The following is a description of a gene set: Mouse Gene Set: RFX2_TARGET_GENES Genes containing one or more binding sites for (Rfx2) in their promoter regions (TSS -1000,+100 bp) as identified by GTRD version 20.06 ChIP-seq harmonization. from publication Yevshin I, Sharipov R, Kolmykov S, Kondrakhin Y, Kolpakov F (PMID 30445619) species: Mus musculus, and this is the list of marker genes: H13, Lrrc49, Mir592, Prkn, Kmt5c (lysine methyltransferase 5C), Gm13856, Pkig, Fez1, Dnah7c, Brca1, Eif4a3, Phc1, E2f5, Zfp688, Calm3, Dyrk3, Ube2u, Ahi1, Get3, Wdr73, Gm19412, 4933427D14Rik, Plcb2, Drc1 (NCBI Gene Id 381738), Tmem270, Lrif1, Ube2o, Pms2, Mir207, Pramel12, Abl1, Krt39, Tnnt2, Eno1b (enolase 1B, retrotransposed), Ctxn2, Mypop, Celf6, Pole3, Lyrm1, Oasl1, 4930419G24Rik, Mtx1, BC048559, Oxnad1, Cby1, Cacybp, Rps3, Atp2b4, Set, 4930455B14Rik, Cfap410, Fam216a, Nsdhl, Wdtc1, Nap1l1, Spats1, Kcnj9, Poli, Cetn2, Iqca1, 4930535L15Rik, Lekr1, Ankrd45, Ccnc, Gm8232, Glb1l2, Ttll3, Gtf2e2, Fscn1, Taok2, Dnal1, Alg12 (ALG12 alpha-1,6-mannosyltransferase), Pank2, Agbl2 (NCBI Gene Id 271813), 1810064F22Rik, Chct1, Mks1 (NCBI Gene Id 380718), Bbs12, Slc25a46, Phc2, Gm1758, Odad3, Spag6l, Cbx8, Dpy19l2, Agtrap (angiotensin II, type I receptor-associated protein), Ak8, Tektl1, Kif3b (NCBI Gene Id 99398), 1700001O22Rik, Tmem107, 4930555B12Rik, Mib2, Zc2hc1c, Gm568, Cep57l1, Gm20716, Me3, Fam229b, Csnk1d, Pkp4, Hras (NCBI Gene Id 15461), Folh1, Mrps9, Psmd13, 1700041I07Rik, Eif2b2, Dctn3, Slc25a3, 1700010I14Rik, Trim2, Ddx41, Pak1ip1, Tsnaxip1, Mocs3, Stk11ip, 1700055D18Rik, Med31, Cinp, Cep290, Map1a, Rps27, Pex11g, Cfap44, Ptges3l, Gm15350, Gzmk, Dpf3, Mlf1, Fam90a1b, Nsmce1, Safb2, Mns1, E330034G19Rik, Ldhal6b, Lrrc46, 4933407I08Rik, Drc3, Gm12474, Rbm5, Gm42722, Cherp, Smg7, Spata7 (spermatogenesis associated 7), Ndufa13, 2810414N06Rik, Srfbp1, Gabarapl2, Kcnip3, 4921504E06Rik, Trip12, Dxo, Fsip1, Pcm1, Spag8, Samd15, Nek2, 4930466I24Rik, Tdrp, Adissp, Iqce, Tiam1, Ube4b, Gtf3c1, Wdr7, Hnrnph2, Smim45, 4930579K19Rik, Mroh9, Zbtb5, Ift172, Zfp667, Eif2s1, Dclre1b, Miat, Mtmr12, Rptoros, 4933417C20Rik, Cdk9, Gm17494, Kcnip2, Stx8, Wdr48, Rnf5, Gm36017 (predicted gene, 36017), Mir1955, Nudc, Ubxn2b, 1700040K01Rik, Tmtc3, 1700023H06Rik, Ttc27, Ap2b1, 2810402E24Rik, Npcd, 1700012B09Rik, Nqo1, 4930507D05Rik, Med25, Zfp664, Akap3, Usp22, 1700029M20Rik (RIKEN cDNA 1700029M20 gene), Cep112, Spmip11, Lca5, Aagab, Cenpj (NCBI Gene Id 219103, centromere protein J), 1700030K09Rik, Yjefn3, Cdiptos, Tbc1d31, Apoo, Ccdc157, Speer4b, Cfap73, 4933405L10Rik, 4930478M09Rik, Dnajc30, Map3k14, Rab27a, Cep162, Pnma8a, Enpp2, Strn4, Bbs4, 1700034J05Rik, Sec16a, Mfsd6, Prepl, Tspyl4, Rgl1, Mir6913, Moap1, Msmo1, Mir7045, Atxn7l1os2, Ino80e, Taf11, 1700028N14Rik, Fam161a, Cep295nl (CEP295 N-terminal like), Fto, Lrrc43, Cfap91, Ufm1, Spmap2l (NCBI Gene Id 71868), Sirt2, Gm11444, Spindoc, Pagr1a, 4933424G06Rik, Gm32780, Jun, Pard3, B9d1, Clba1, Ccdc166, Atp6v1d, Tubb4b, 1500009L16Rik, Nkiras2, Glipr1l1, Bcar3, Rbl2, Speer4e2, Gm10433 (NCBI Gene Id 100038378), Celf5, Gas8, Ttc29, Myadm, Cfap144, Dync2h1 (dynein cytoplasmic 2 heavy chain 1), Tmem150c, 4930445N18Rik, Traip, Ttc41, Dennd4b, Gpr107, Fkbpl (FK506 binding protein-like), Zfp386, Calm2, Ppp1r7, Zfp819, Rilpl2, 4930590L14Rik, Izumo3, Tspoap1, 4930556G01Rik, Ap2a1, Txlna, Arf3, Tor2a, B9d2, Mir219c, Skic2, Ccbe1, Bin3, Igsf11, Tsga10, B230307C23Rik, 1700111E14Rik, Cers1, Acox3, Grb10 (NCBI Gene Id 67977), Rnf41, Tm9sf1, Wdr90, Tmem225, Rpgrip1l (Rpgrip1-like), Hmgn2, Agbl4, Ttll8 (tubulin tyrosine ligase-like family, member 8), Riiad1, Ccdc184, Phyhipl (phytanoyl-CoA hydroxylase interacting protein-like), Crnde, Tada2b, Gm15564, 1700021P04Rik, Meaf6, Sema4a, Spint1, Ddx31, Rlf (rearranged L-myc fusion sequence), Golm2, Tmx4, Ankrd42, Gm16001, Hoatz, Gm38505, Ift81, Ccdc107, Gm15935, Ybx2 (Y box protein 2), Drc7, 4933430I17Rik, Ints4 (integrator complex subunit 4), Lman2l, Hirip3, Micos10, 4930503O07Rik, Fam76a, 1700010K24Rik (RIKEN cDNA 1700010K24 gene), Pex11a, Lins1, Dcaf12, Trip4, Pbx4, Tmem167b, Nol4, Efl1, Wrap53, Flacc1, Ebna1bp2, Crispld2, Figla, Dcaf15, Ulk4, 1700072G22Rik, Gm40293, Osbpl10, Cfap96, Pspc1, Fam81a, Ccdc92, Tmem209, Gm3764, Fbxw9, Itgb3bp, Actl7b, 1700018A04Rik, Gm14963, Mrpl22, Mcm10, Mex3c, Ech1, Gm14999, Dad1, Fuz, Tbcd, Taf1, Tmem53, Ino80c, Rnf25, Armh1, Alkbh5, Arl4aos, Psmc3ip, Meig1, Sec61a2, Gm10044, Bud23, Gykl1, Btrc, Meak7, Spata46, Cracd, Gtf2f1, Chchd3, Lrriq4, Mbd4, Abhd17b, 4930432L08Rik, Prss44, 4930562C15Rik, Sde2, Ift56, Gm20732, Kdm6b (KDM1 lysine (K)-specific demethylase 6B), Ltbp4, Myo1b, Chd4, Rtca (NCBI Gene Id 99635), Akirin1, 4930519G04Rik, 4930423M02Rik, Dzip1, Gm8127, Rab36, Dach2, Odad4, Gm4876, Sys1, Arl3, Ift57 (NCBI Gene Id 73916), Mapk10, Tfeb (transcription factor EB), Tecpr2, 1700030A11Rik (NCBI Gene Id 74179), Sh2d6, Trpm1, Pds5b, Sv2c, Qpctl, Pofut2, 4930467D21Rik, Gm17078, Dync2i2, Calr3, Shq1, Chn1, Plxnb1, Agpat1, Nphp1, Rsrc2 (arginine/serine-rich coiled-coil 2), 4930562A09Rik, Morn5, Prrt2 (NCBI Gene Id 69017), Snip1, Lyrm7, Gla, Ap1m1, 4930563E22Rik, Atp10d, Hc, Coq6, Rfx4, Spaca9, Efhd2, Ptpn4, Mthfr, Fbxw7, Usp2, Zfp715, Enox1, Ppil6, Daw1, Sik1, Lyrm4, 4930547M16Rik, Ccdc65, Map9, Pask, Mipepos, Dusp6, Dusp3, Syngap1 (synaptic Ras GTPase activating protein 1 homolog (rat)), Plin5, Dhx32, Acer2, Zfp653, Cep19, Rgs22, Ppm1g, Zbtb40, Lcorl, Reep6, Dab2ip, Kti12, Ndufb5, Arrdc3, Qars1, Gtf3c4, Psma5, Pabir3, 4930568G15Rik, 1700029J03Rik, Naa11, Copb2, Zfp37, Gm17690, Cabin1, Ank2, Cstpp1, AI429214, Anks3, Kif24, Bbs9, Erich2, Tekt4, Tapbp, Spef1, Prkar1a, Klhdc9, 4930407G08Rik, 1700109G14Rik, Sirt3, Ap4m1, Spata6l, Fbxo36, Cabcoco1, Brms1, Krt73, 1700084C06Rik, Mon1b, 4930571K23Rik, Spag1, Cep89, 1700041G16Rik, 4930522H14Rik, Prkar2b, Elapor1, Kif1b, Akap11, Cox20, Zbtb48, Pbdc1, Bbs7, Fam98b, Ap1s1, Ttc39d, Prkar2a, Cops3, Dpcd, Desi2, Snrpf, Myo10, 4933434M16Rik, 1110059E24Rik, Snord15a, Nemp1, Timm13, Mir92b, Rpl22l1, Tmem216, Rer1, Cfap20dc, Cep135, Dyrk1b, Fam227b, Zdhhc23, Marchf3 (membrane associated ring-CH-type finger 3), Gm36831, Pef1, 4921536K21Rik, Erich6b (NCBI Gene Id 75272), Ccdc96 (NCBI Gene Id 66717), E2f8, Pierce2, Ntmt1, Mall, 1700037C18Rik, Dixdc1, Ccdc126, Rfx3, Ccdc103, Cfap52, Pnkp, E2f3, Brat1, Mafg, Gm10555, Trmt61a, Sik3 (NCBI Gene Id 77161), Gstz1, Pi4k2a, Supt6, Rrp7a, 4930572K03Rik, Gm10862, B9d1os (B9 protein domain 1, opposite strand), Plod3, Cfap119, Gm5218, Spata4, 9330198N18Rik, Kcnq1ot1, Pabpc4, Mpp2, Lrriq1 (NCBI Gene Id 74978), Rpgr, Baiap2, Atp6v1a, Ccdc148, Neurl1a, 4933438B17Rik, Gm20610, Tekt3, Znhit1, Stk19, Ift88, Gm28783, Gpatch2, Wdr13, Kifbp, Rnf138rt1, Iqch, Cwc25, Sipa1l1, Edem3, Cystm1, Ribc2, 1700073E17Rik, Hspa1l, Trpm2, Adsl, Mtr, Rpl24, Phtf1, Mipep (mitochondrial intermediate peptidase), Dnaaf11, Smpd4, Gsdme, Eftud2, 2610035D17Rik, Mtss2, Ak9, Gm9837, Stam2, Gm6401 (NCBI Gene Id 623168), 1700008O03Rik, Orai2, Wdpcp, Gm15172, 6820408C15Rik, Mir3083, Rsph14, Rptor, Cryzl1, Mapk7, Enkur, Thg1l, 4921507G05Rik, 9130204K15Rik, Cfap53, Efcab12, Nme7, Bcl2l14, Baiap3, Uvrag, 4930453O03Rik, Dusp13b, Celf3, Aspm, Wdr54, Dnajb2, Otub1, Ccdc102a, Nrxn2 (neurexin II), Hmgcr, Cln3, Bcap31, Gemin8, Senp1, Kif6, Fam135b, Pla2g2c, Cfap206 (cilia and flagella associated protein 206), Hspb6, Dph3, Ppm1d, Zfp287, Ndufs3, Lmtk3, Smkr-ps, Gm13449, Dcp1b, Cfap46, Aff3, Cngb1, Ccdc175, 4933435F18Rik, Jakmip2, Spice1, Ift22, Dnai2, Gm12299, Rnf40, Iftap, Mafa (NCBI Gene Id 378435), Rpa3, Cfap97d2, Rnf182, Taf15, Sh3gl3, Cfap126, Traf3ip1, Arhgef40, 1700024B18Rik, Ralgapa1, Ccdc60, Grm3, Tmem8b, 1600012H06Rik, Gm7181, Lsm10, Ndufaf7, Cdipt, Tle6, Klhdc10, Lrrc37a, Dnaaf4, Lrrc24, Stk32c, Prkcsh, Bola3, Ift70a2, Slf1, Cyb561a3, Usp12, Rab28, Wdr17, Naa50, Morn4, Slmapos2, Whrn, Ak1, Cipc, Pex12, Setd4, 1700049L16Rik, Pes1, Dync2li1, Peli1, Ppm1e, Usp30, Tekt2, Arpc5, Fam227a, Spef2, Cfap74, Tfip11, Cacng8, Rabl2, Pex5, Dagla, Ubl3, Zp3r, Otud5, Fam204a, Copz1, Dnal4, Btbd16, Mpc1, Ywhaz, Nkapd1, Col19a1, Bbs1, Faap24, Pnma8b, Kif20b, Ppp2r3d, Gnl2, Igsf9, Tom1l2, Spata6, Kcnu1, Acyp1 (NCBI Gene Id 66204), Cetn4, Etv1, Tpm3, Ccdc13, Ruvbl1, Zswim2, Dnajc10, Stk16, Ttll1, Ift70b, U2af2, Msh5, Ccdc191, Thop1, Gm16230, Spag17, Tbpl1, Banp, Actr6 (ARP6 actin-related protein 6), 4933404O12Rik, Mlec, Oscp1, Dusp18, Actr1b, Actrt1, 1700125G22Rik, Nap1l3, Pold3, Jmjd8, Rpl30, Znrd2, 4930519D14Rik, Pnkd, Ttll13, Pdgfa, 4933431K23Rik, Gm9758, 1700028E10Rik, Slc25a14, Camk2a, Abhd4, Josd2, Ccnt1 (cyclin T1), Odc1, Micos13, Tufm, Tasp1, Trim37, Jam3, Dpysl5, Spag16, 1700109I08Rik, Tpte, Ufsp2, Ring1, Ppp2r1a, Ccdc150, Hspa1a, Mapre3, Arrdc4, Rab3il1, Fam131a, Ttll10 (tubulin tyrosine ligase-like family, member 10), Mdh1, Gm20647, Ccdc30, Yeats2, Snora57, Sox30, Spata45, Pitpnm2, Mrpl10, Mia3, Cfap77, Sel1l2, Gm13712, Cdc42bpa, Gmppb, Ift43, Ido2, Ankrd69, Dym, 4930405H06Rik, Saxo2, Qtrt2, Carmil1, Zfp184, Fam83h, Dnah1 (NCBI Gene Id 630521), 2210408I21Rik, Tmem67, Ipo4, 1700003M07Rik, Tceal3, Clxn, Nbr1, Ankfy1, BC061237, Vrk3, Bud13 (BUD13 homolog), Tpcn2, Dffb, Fig4, Shank3, Clcn6, Tppp3, Mir2861, Cxxc1, Akr1e1, Rspry1, Zfp407, Lrrc73, 1700021N21Rik, Foxo6, Kntc1, Trp53rkb, Nacad, BC025920, Cfap161, St13, Tmem9, 4930526F13Rik, Rhpn1, Angel1, Ankrd6, Cars1 (NCBI Gene Id 27267), Nabp2, Pak4, Naa20, Cfap95 (NCBI Gene Id 67483), Gm7069, Ttc12, Liat1, Ptpn21, 1810009A15Rik, Nek11, Pyroxd1, Fam32a, Rtl6, Mettl15, Pick1, Dtwd1, Pigt, Pde9a, Golgb1, Ccdc81, Cyth2, Heatr4, D130043K22Rik, Gm9929, Proser3, Cfap20, Lrrc74b, Vcf2, Ccdc42os, Wbscr25, Cimip1, Rpp38, Hspa4l, Atosa, Ywhaq, Usp21, Dnaaf3, 4930554G24Rik, Fam53b, Spcs2, Tnpo1, Mzf1, Gpatch4, Alyreffm1, Gk2, 4930580E04Rik, Qsox2, Gm26705, Doc2a, Fam234a, 1700113B19Rik, Gm16853, Dnai4, Lmntd2, Tmem231, Casp6, Macrod2, Tmem219, Tm4sf5 (NCBI Gene Id 75604), Galk2, Ppp5c, Rmrp, 4930550C14Rik, Cdkl3 (NCBI Gene Id 213084), Zfat, Mcm7, Dhx40, Smarcad1, Tmed8, Kcnip4, Cimap3, Flad1, Ppp1r21, Lss, Pfkfb1, Cyp46a1, Pcsk4, Arl6, Klhl18, Plekhd1, Ect2, Kbtbd4, Ipo11, Mindy4, Klhl28, Cd82, Gm11767, Asz1, Prdm4, Sec13, Hmcn1, Deup1, Xpr1, Cfap221, Gen1, Ccdc180, Trim41, Hsp90aa1, Blzf1, Cep41, Tmed10, Mink1, Smdt1, Mok, 4931429L15Rik (RIKEN cDNA 4931429L15 gene), Ppp1r11, Fgd3, Cfap45, Morn1, Cfap54, 4931403E22Rik, B230369F24Rik, 1700058P15Rik, Dhx16, 4933417D19Rik, Sf3a1, Fank1, Ndufa12-ps, 1700003H04Rik, Per1, Agbl3, Hydin (HYDIN, axonemal central pair apparatus protein), Myo18a, Dnai7, Camk2d, Speer4a1, Cbx6, Rfx1, Naga, Nme5, Derl1, 1700112D23Rik, Lrrc34, Mrpl53, Glrp1, Tomm7, Notch4, 1700104B16Rik, Smc6, Ttc23l, Pin4, Glt8d1, Ap3d1, 4933407L21Rik, Gm42161, Arl2bp, Tpgs1 (NCBI Gene Id 216149), Polr3h, Tubgcp3, Trp53rka, Siva1, Cfap36, Cfap251, Pold2, Atf6, Mthfd2l, Dnajc1, Zbed5, Sdc3, Fndc11, E4f1, Dnaaf5, Dlg4, Snord71, Tctn1, Bdp1 (B double prime 1, subunit of RNA polymerase III transcription initiation factor IIIB), Tmem218, Lyst, Tbcel, Ttc8, Arid4a, Grwd1, Azin2, Cfap43, 0610009E02Rik (NCBI Gene Id 100125929), Tex21, Rnf126, Dis3, Dmwd, Iqcg, Srsf7, Mpnd, Mak, Zfp459, Psmd8, Tube1, Ptpn13, Ubxn10, Ppp1r42, Cdk4 (NCBI Gene Id 12567), Rae1, Gm5577, Tbc1d19, Ttc6, Map10, Cand1, Knop1, 4930417O22Rik, Spmap2, Lingo1, Potefam1, Apc2, Tm9sf5, Ccp110, Cnpy3, 1700066J03Rik, Pik3cd, Net1, Gm14437, Leng8, Ankmy1 (ankyrin repeat and MYND domain containing 1), Ddx24, Txndc17, Ift122, 3110082I17Rik, Gm15728, Gfer, Ccdc142os, Myg1, Vcp, Spcs1, Cfap70, Matcap2, Coq8b, Ogfod2, Bad, 1700030C14Rik, Nsun7, Abhd2, Gck, Numb, Znrf1, Dnajb13, Bicdl1, Stox1, Gnas (GNAS complex locus), Mcmdc2, Clpx, Gnaz, Tent5c, Katnip, Dnajc25, Ift74, Cdc37, Aste1, Catsperg2, Ube2c, Ms4a20, Rfc2, Ptges2, Sdccag8, Lpin2, Phospho2, Fzr1, Dohh, Zmat2, Nucb2, Cfap276, Zfp512, Cep152, Junos, Gnl1, Man1b1, Gm2788, Slc25a23, Slc14a2, Rpf2, Rps6kc1, Iqsec1, Ssbp3, 1700054K19Rik, Cfap97d1 (CFAP97 domain containing 1), Sdcbp, Dcun1d3, Tmem89, Csnk1g1, Gm2449, Pcdhb1, Rpl35, Marchf8, Cacna1a, Zbtb11, Cep104, Pih1d2, Creld2, Pcf11, Shoc2, Ankrd48, Klf13, Dydc1, Pbx3 (pre B cell leukemia homeobox 3), Alms1, Cep128, Hdac5, Marchf10, Dnah9, Nfkbib, Ccdc39, Gm6558, Mir5136, Polr2f, Dynll1, Zc3h10, Ctxn1 (NCBI Gene Id 330695), 1700003E16Rik, 4930505A04Rik, Bbs5, AI467606, Nudt2, Armc3, Dnajc16, Ints5, 4930404A12Rik, Ccer1, Rcl1, 5530601H04Rik, Spata2 (spermatogenesis associated 2), Zfp768, Cmpk2, Chmp1a, Wiz, Clcn3, Gm9791, Cwf19l2, Slc43a2, Ip6k2, B3galt5, Gm10532, Prkar1b, Wwox, Dnajc7, Prr3, Cdk20, Gnb2, Gm11457, Timm10, Mdga2, Epb41l4a, Cfap418, Crnkl1, Mid1ip1, Gm33474, Mgat1, Cfap65, Ubxn11, P4ha2, Phf20, Ccdc113, Ptdss2 (phosphatidylserine synthase 2), 4931415C17Rik, Hat1, Prmt5, Dynlt2b, Ankrd54, Dnaaf6rt, Gorasp1, Tekt1, Cog7, Ccdc34, Cfap90, Pim2, Nsmf (NCBI Gene Id 56876), Gm15587, 1700074A21Rik (NCBI Gene Id 73482), Mir9769, Tmem184c, Zeb1, Stoml2, Gm5444, Ipmk, Tbc1d32 (TBC1 domain family, member 32), Tenm4, Cenpf, Cplane2, Wdr93, Ttll9, Pheta2, Dcaf6, Gpr135, Sfr1, Ccdc32, Rsph1, Samt3, 1700088E04Rik, 3110056K07Rik, Gpn3, Kdm4a, Syce3, Fhad1, Cfap298, Trp53bp1, D030047H15Rik, Gpr137, Fam167a, Dlec1, Morn2, Nelfe, Emc4, Mboat7, Wdr31, Ccno, 4933430H06Rik, Naa40, Nr1h2, Rpl35a, Scml4, Dnaja1, Cfap61, Speer4c1 (spermatogenesis associated glutamate (E)-rich protein 4C1), Gm13830, Fam120b, Atp5f1a (ATP synthase F1 subunit alpha), Arl4a, Tcp11, Cep170, Tmem232, Pfn2, 4931419H13Rik, Sertad3, 1700064M15Rik, Capn10, Pnma1, Ddx39b, Cfap57, Dnah11, Jam2, Cpd, Gm25308, Cpt1b, Cfap58, Sh3bp1, 1700034K08Rik, Amz2, Syt5, Cdkl5, Rgs3, Qtrt1, Pigx, Rpn1 (ribophorin I), Elmod2, Lrrc27, Zfp523, Cmtr2, Cdk2ap2, Got1l1, Hsph1, Spout1, Zmynd10, Gm11802 (NCBI Gene Id 102636258), Xrra1, Ccnh, Orai3, Armc9, Mir3960, Crip2, Ywhae, Tmem237, Eaf2 (NCBI Gene Id 106389), Spata33, Camkmt, Ssmem1, Ccdc146, Tex47, 4933411O13Rik, Rhbdl1 (NCBI Gene Id 214951), Hpcal4, Fam110a, 5730480H06Rik, Tnfrsf19, C130026L21Rik, Gm15579, Foxn2, Slc35a2, Arf2, Fgf20, Lrrc23, Efcab2, Ankef1, 1700029H14Rik, Tctn3, Gm11981, Gm1123, Nicn1, 1700042O10Rik, Syt6, Hdgfl1, Mycbp, Senp2, Btbd17, Nav2, Rnf141, Fbxl18, P4ha1, Saxo4, H2-Eb1, Prss54, Smpd2, Ccdc110, Eif5a2, Ccdc158, Cfap300, Smc1b, Efcab6, Cimip4, Atp5f1e, Asb7, Odf2, Cfap69 (NCBI Gene Id 207686), Rrp12, Trim34a, Siah2, Zfyve28, Ndufa8 (NADH:ubiquinone oxidoreductase subunit A8), Fntb, Entpd1, Gm11837, Dnali1, Zfp46, Gm32950, Cox11, Ubn2 (ubinuclein 2), Rsph9, Foxj1, Ankrd7, Ppp1r15b, Mapkbp1, Prpf19, Ptpn6, Dnai3, 1700030J22Rik, Tedc1, Gm25588, AU041133, Rnf32, Pik3r2, Best1, Dalrd3, Mir760, Tbc1d10a, Rfx2, Lrrc56, 1700007J10Rik, Ccdc8, Gm4419, Trim33, Zfp719, Zfp24, Poll (polymerase (DNA directed), lambda), Sfxn2, Pin1, Gde1, Ephb3, Akap9, Gm7337, Iqank1, Sec22c, Cdkl1, Cd2, Ireb2, Rbms1, Gm17174 (predicted gene 17174), Gm20513, 1700012C14Rik, Ap2s1, Cpne5, Ccdc42, Ift52, Inpp4a, Sgta, 1700018F24Rik, Gpatch2l, Etfrf1, Kif23, Siah1b, Mir7666, Uhrf1, Ccdc138, 1500035N22Rik, Cep120, Gm34768, Got1, Ubxn6, Fanci, Hmgcs1, Vwa3b, Togaram1, Gm10941, 1700006A11Rik, Spef1l, Kif9, Rsph4a, Ccdc59, Csnk1g2, Med9os, Gm21149, 1700025B11Rik, Dyrk1a, Kpna6, Igbp1b, Arfip1 (NCBI Gene Id 99889), 1700036G14Rik, Cimip2c, Thnsl1, Phtf1os, Ip6k1, Pdcl2, Ttc21a, Ccdc169, Med9, Cacfd1, Dpm1, Cebpz, Gpkow, Wbp11, Dmxl2, Mus81, Oprl1, Gm13267, Wdr35, Rfc5, Pcgf1, 4930480C01Rik, Usp29, Hipk4, Klf2, Eef2kmt (eukaryotic elongation factor 2 lysine methyltransferase), Fam185a, Lztfl1, Dnaaf2, Gm16017, Ehd1, Dnah10, Ms4a13, Znhit2, Dnah6, Apobec4 (apolipoprotein B mRNA editing enzyme catalytic polypeptide-like 4), Map6, Ap4b1, Arhgap1, Phaf1, Jkampl, Kif18a, Braf, Odad2, Xpnpep3, Glb1l (galactosidase, beta 1-like), Rufy1 (NCBI Gene Id 70206), Sorbs2, Stxbp4, Zbbx, Adarb1, Rusf1, Clec2m, Dis3l (DIS3 like exosome 3'-5' exoribonuclease), Slc4a8, Trit1, Kiz, Pcnx4 (NCBI Gene Id 67708), 4933434E20Rik, Dynlrb2, 1700047F07Rik, Cluap1, Etfbkmt, Ncoa2, Peg3, Ranbp10, Intu, Katnb1, Trub2, Itsn1, Snrpd2, Ncoa5, Efhb (NCBI Gene Id 211482), Cops2, Iqck, Tspyl5 (testis-specific protein, Y-encoded-like 5), Ccpg1, Kcnc1, Mpc2, Ccdc181, 4930515L19Rik, Ccna1, Zfp473, Erich6, Tex9, Tex26, Ano3, Hmox2, Mfsd4b4, Ankrd13d (NCBI Gene Id 68423), St18, 1700001G01Rik, Dnah7a, Coq4, Arl14ep, 4930505G20Rik, Gm12712, 1700027A07Rik, Pcsk1n, Rundc1, Lmbrd1, Ccdc73, Lkaaear1, Stk36, N4bp2l2, Ccdc192, Hsp90b1 (NCBI Gene Id 22027), Impg2, Wdfy1, Efcab7, Cep164, Mtmr6, Lrguk, Nup50, Caps2, Enkd1, Zc3h3 (zinc finger CCCH type containing 3), Churc1, Catspere2, Zfp444, Dbn1, Rpn2, Mier1, Gabrg1, Dip2b, Ccdc57, Zfp446, Asb1, Tm9sf4, 4930526L06Rik (RIKEN cDNA 4930526L06 gene), Krtap24-1, 4930434B07Rik, Gm7361, Mul1, Cibar2 (NCBI Gene Id 436062), Catsperg1, Zswim1, Gm11992, Spg21, Iqub, Psme3ip1, Spata17, Gm40292, 4930564D02Rik, 4930540M05Rik, Mir132, Lbhd1, BC049715, Ndufs5, Dennd2a, Ssbp2, Sf3b4